Given this list of marker genes Ehd3, Stac2, Nipsnap2, Fgf14, Stac3, Cacnb3, Stac, Cacnb2, here is a description of the gene set: studied in species Mus musculus Any process that activates or increases the frequency, rate or extent of voltage-gated calcium channel activity. Mouse Gene Set: GOBP_POSITIVE_REGULATION_OF_VOLTAGE_GATED_CALCIUM_CHANNEL_ACTIVITY